Given this list of marker genes CMPK1, UCK1, UPRT, CDA, UCK2, UMPS, DCK, UPP2, DHODH, UCKL1, CAD (NCBI Gene Id 790), UPP1, here is a description of the gene set: Human Gene Set: GOBP_PYRIMIDINE_RIBONUCLEOSIDE_MONOPHOSPHATE_BIOSYNTHETIC_PROCESS studied in species Homo sapiens The chemical reactions and pathways resulting in the formation of pyrimidine ribonucleoside monophosphate, a compound consisting of a pyrimidine base linked to a ribose sugar esterified with phosphate on the sugar.